Given this list of marker genes SHOC2, CORO1A, CSTF2, EHD1, SH3GL2, E2F1, LCN2, PTPN1, RAPGEF2, KAT2A, GRIA1, NGF, EIF4A3, MAGI2, BPTF, EEF2, ARPC3, HES1, USP8, TMEM108 (transmembrane protein 108), DYNC1LI2, WASF1, NTRK1, RAPGEF1, ACAP2 (ArfGAP with coiled-coil, ankyrin repeat and PH domains 2), NTF4, CSNK1E, APP, CBL, ARF6, RAB35, KCNC2, NTRK3, CREB1, KCNC1, TAC1, CD2AP, STMN2, AKT1, KIDINS220, NTF3, EEF2K, BDNF, CIB1, FOXO3, SORT1, MAPT, NTRK2, CRK, PARP1, CALCA (NCBI Gene Id 87044), RAP1A, here is a description of the gene set: A process that results in a change in state or activity of a cell or an organism (in terms of movement, secretion, enzyme production, gene expression, etc.) as a result of a nerve growth factor stimulus. Human Gene Set: GOBP_RESPONSE_TO_NERVE_GROWTH_FACTOR species: Homo sapiens